Given this list of marker genes MIR30C1, MIR548P, MIR185 (NCBI Gene Id 406961), CH25H, ERLIN1, MIR27A, INSIG1, C7orf50, SCAP, ERLIN2, MIR342, APOE, MIR98, MIR27B, here is a description of the gene set: studied in species Homo sapiens Any process that decreases the rate, frequency, or extent of cholesterol metabolism, the chemical reactions and pathways involving cholesterol, cholest-5-en-3 beta-ol, the principal sterol of vertebrates and the precursor of many steroids, including bile acids and steroid hormones. Human Gene Set: GOBP_NEGATIVE_REGULATION_OF_CHOLESTEROL_METABOLIC_PROCESS